The following is a description of a gene set: species: Homo sapiens Human Gene Set: GOCC_AP_1_ADAPTOR_COMPLEX A heterotetrameric AP-type membrane coat adaptor complex that consists of beta1, gamma, mu1 and sigma1 subunits and links clathrin to the membrane surface of a vesicle; vesicles with AP-1-containing coats are normally found primarily in the trans-Golgi network. In at least humans, the AP-1 complex can be heterogeneric due to the existence of multiple subunit isoforms encoded by different genes (gamma1 and gamma2, mu1A and mu1B, and sigma1A, sigma1B and sigma1C)., and this is the list of marker genes: AP1S3, AP1G2, CLBA1, AP1S1, AP1M2, SYNRG, AP1B1, AP1G1, SLC18A3, AP1S2, AP1M1 (NCBI Gene Id 8907), AFTPH